The following is a description of a gene set: In the present study we used Affymetrix oligonucleotide microarrays to produce gene transcription profiles for the major leukocyte types in humans. This comprehensive dataset enabled us to not only establish which genes were expressed in each leukocyte type, but also which genes were expressed in each subset after activation. The used of a comprehensive dataset of gene profiles from all the major human leukocyte subsets enabled a novel and powerful means for identification of genes associated with single leukocyte subsets, or different immune paradigms. Genes down-regulated in comparison of B cells versus Th1 cells. from publication Jeffrey KL, Brummer T, Rolph MS, Liu SM, Callejas NA, Grumont RJ, Gillieron C, Mackay F, Grey S, Camps M, Rommel C, Gerondakis SD, Mackay CR (PMID 16474395) Human Gene Set: GSE3982_BCELL_VS_TH1_DN studied in species Homo sapiens, and this is the list of marker genes: STARD13, TYMS, ATP2B4, GZMB, ITK, WDR76, LCT, SPSB1, SLC31A1, GIPR, TST, RNF24, SLC43A3, NDUFS1, FKBP5, ADIPOR2, SMAD7, JPT1, LAIR2, HBEGF, ZBED2, WNT11, APBB2, ABCA2, GTSE1, PHACTR2, ATP9A, CEP170B, TNFRSF9, AK4, QPRT, ELAC2, DLGAP5, MPP1 (NCBI Gene Id 4354), FANCG, TRAC, FAM200C, APOD, BTG3, CD28, SMAD5, FUS, CLSPN, GADD45A, UGGT1, KPNA2, AFF4, PDGFA, MRPL16, ZBTB43, DTYMK, TAP2, RRM2, PPP1R3A, MAMLD1, AMMECR1, NGDN, GZMM, PLK1, DYNLT1, CDC123, TPSG1, SLC6A15 (NCBI Gene Id 59276), APOBR, PITPNM1, SPP1, HOPX, GBA1LP (glucosylceramidase beta 1 like, pseudogene), CYP46A1, ZCCHC24, WSB2, KIF2C, U2AF1 (NCBI Gene Id 7309), ITGA2, CDC25A, HMBS, FNDC3B, CEBPA, ENY2, CCL4, MAL, PDE3B, SLC25A22, RPRM, ELOVL6, IL15RA, TMEM106C, POGLUT2, ZNF207, ACOT7, ANXA3, TRPV4, GTF2H5, BUB1, HACD1, FLOT1, GRPEL1, EPS8L3, TWSG1, SPRY2 (NCBI Gene Id 10253), COPZ2, NDN, TXNL1, CST7, SPAG5, PAQR4, RRM1, NEIL3, RBM28, PXMP2, CD247, RAD23B, DCTN5, NECTIN3, FOXM1 (NCBI Gene Id 2305), ST3GAL6, CKS2, LRFN4, BUB1B, GMEB1, NAP1L4, SFXN1, REEP4, NEFH, PLK3, ZWILCH (zwilch kinetochore protein), EGFL6, RPS6KA3, FABP5, MPIG6B (megakaryocyte and platelet inhibitory receptor G6b), MYH10, CTTN, IPCEF1, DGKI, KCNS3, PTTG1 (PTTG1 regulator of sister chromatid separation, securin), PARD3, SQOR, NUP155, LRP1B, RAB11FIP5, FN1, RBM47, CBS, CDH9, CLIP4, SECTM1, NUPR1, BHLHE40, EXOC6B, BAG2, SCD, GOLGA2, CORO2A, PRC1, RAB11A, MUC1, STEAP1, IL18RAP, NSD2, KIF4A, ZNF91, EVC, SPC25, MFGE8, C21orf91, AGK, RNF19A, NCAPG, SLC22A1, FOSL1, NASP, IFT56, HBE1, MCUR1, TNFRSF25, ARL3, MKLN1, DNASE2B (NCBI Gene Id 58511), PPIF, BAHCC1, MRC2, HELLS, TAP1, UTP11, ITM2A, KIFBP, BARD1, SAP30, OPTN, MT3 (NCBI Gene Id 4504), PTGIR, ASF1B, GPR63 (G protein-coupled receptor 63), HK3, NRP1, HMGB3, MTCH2